Given this list of marker genes PBX1 (PBX homeobox 1), SP1, NR4A1, CREB3L1, CYP11B1, CREB3L3, CREB5, CREB3L2, NR5A1, ATF2, ATF4, ATF6B, CREB3, PRKACA, CREB1, CREB3L4, STAR, here is a description of the gene set: Mutation-activated PRKACA to ACTH-cortisol signaling pathway. Pathway ID: N00320. Pathway type: Variant. Pathway class: nt06360 Cushing syndrome. Human Gene Set: KEGG_MEDICUS_VARIANT_MUTATION_ACTIVATED_PRKACA_TO_ACTH_CORTISOL_SIGNALING_PATHWAY Pathway Definition from KEGG: PRKACA* -> (NR5A1,NR4A1,SP1,PBX1,CREB) => (STAR,CYP11B1) -> Cortisol studied in species Homo sapiens